The following is a description of a gene set: Mouse Gene Set: ZENG_GU_POST_ICB_METAGENE_41 Most patients with cancer are refractory to immune checkpoint blockade (ICB) therapy, and proper patient stratification remains an open question. Primary patient data suffer from high heterogeneity, low accessibility, and lack of proper controls. In contrast, syngeneic mouse tumor models enable controlled experiments with ICB treatments. Using transcriptomic and experimental variables from >700 ICB-treated/control syngeneic mouse tumors, developed a machine learning framework to model tumor immunity and identify factors influencing ICB response. Projected on human immunotherapy trial data, found that the model can predict clinical ICB response. further applied the model to predicting ICB-responsive/resistant cancer types in The Cancer Genome Atlas, which agreed well with existing clinical reports. from publication Zeng Z, Gu SS, Wong CJ, Yang L, Ouardaoui N, Li D, Zhang W, Brown M, Liu XS (PMID 36240281) Metagene derived from the post-Immune checkpoint blockade treated samples. Significance of the post-ICB sample metagenes was not discussed in the study. species: Mus musculus, and this is the list of marker genes: Zfp938, Tomm40l, Haus2, Sephs1, Tex30, Cdc123, Prss41 (NCBI Gene Id 71003), Tex9, Pcyox1, Enkur, Ldah, Rabl2, Smu1, Tfb2m, Oxr1, Map3k7, AU041133 (expressed sequence AU041133), Capn10, Dnal1, Tfam, Zfp410, Mff, Ndufaf1, Agbl2, Zfp808, Zfp870, Bbs10, Serpini1, Zwint, Plppr4, Hcfc2, Fbxw2, Mapk8, Eif3l, Arhgap21, Zfp975 (NCBI Gene Id 434179, zinc finger protein 975), Dnajc10, Arsk, Sp3, Kansl3, Ppp2r5e, Ergic2, Odf2l, Nhsl1, Notum (NCBI Gene Id 77583), Twsg1, Nedd1, Sdhc, Zgrf1, Ptdss2, Hjurp, Poc1b, Scyl1, Kctd20, Rnft1, Fancl, Impa1, Pdcd10, Trmt10b, Fbxo5, Ttc23, Rnf34, Zfp229, Pde7a, Zfp81, Zfp983, Mdm1, Med24, Tbp, Mob4, Pank2, Zfp933, St6galnac2, Eya2, Pspc1, Dennd6a, Ranbp17, Eif4e, Mesd, Stk33, Dhx57, St7l, Cnnm3, Oxnad1, Pex3, Ppp2r3c, Primpol, Rnf207, Esco2, Zfp1006, Psmc6, Bbs4 (NCBI Gene Id 52291), Zfp946, H60b, Ube2e3, Galc, Bbs7 (NCBI Gene Id 71492), Vta1, Fam227a, Cnot2, Kbtbd4, Sin3a, Lztfl1, Actr10, Nars2, Setd3, Yars2, Chm, Phf3, Usp54, Arl6ip6, Ston1, Hnrnpr, Zfp874b, Prps1l3, Zfp93, Zfyve1, Cplane1, Zfp955b, Spice1, Xrcc3, Wdr73, Fam149b, Wars2, Pih1d2, Lin52, Card6, Cplane2, Zfp868, Mapk1, Dnajc24, Acadsb, Poglut3, Cenpl, Psmd6, Ppp3cb, Ap3m1, Sumo3, Ints8, Rrm2b, Cops8, Ankrd13c, Tctn1, Nme7 (NME/NM23 family member 7), Kansl1l, Moap1, Mtor, Lrrc40, Zfp426, Pnpla8, Sh3bp5l, Ipo9, Mettl6, Fsd1l, Hoxa6 (homeobox A6), Zfp760, Dedd, Mapre1 (microtubule-associated protein, RP/EB family, member 1), Dcun1d1, Orc4, Tbc1d15, Skida1, Ift88, Iqcd, Mbip, Zfp874a, Tiprl (NCBI Gene Id 67837), Zfp433, Srsf3, Ppp1r7, Zdhhc20, Ift80, Med7, Ttll4, Rasa2, Nt5c2, Kcnk5, Zfand4, Alg13, Akt1, Pign, Fgd6, Ahsa2, Drg1, Btbd9, Acsl4, Chek1, Wdpcp, Zfp119b, Plk4, Rps6ka5, Cyb5d1, Cul3, Prxl2c, Glo1, Dclre1b, Dlgap1, Ctnnal1, Casd1, Mynn